Given this list of marker genes CX3CR1, C3AR1, CSF1R, MIR128-1, CYP19A1, SLAMF8, PTPRJ, CCR2, CD9, CD200R1, TNFSF18, CD200, EMILIN1, CMKLR1, CX3CL1, CCL3, P2RY12, P2RX4, MTUS1, CCL2, CD81, TREM2, DDT, BCR (NCBI Gene Id 729775), PTK2, MMP14, IL34, RTN4, CXCL17, C5, MDK, C5AR1, STAP1, MAPK1, MAPK3, CSF1, CCL5, PTK2B, MMP28, TRPV4, MIF, AKIRIN1, CNN2, MSTN, SLAMF1, RARRES2, THBS1, MIR24-1, here is a description of the gene set: Any process that modulates the frequency, rate or extent of macrophage migration. Human Gene Set: GOBP_REGULATION_OF_MACROPHAGE_MIGRATION species: Homo sapiens